Given this list of marker genes Spire1, Avp, Golph3, Bbc3, Ep300, Mgarp, Hdac6, Psmd10, Rala, Lmna, Hrk, Dcn, Gclc, Bax, Tmem102, Vat1, Dhodh, Moap1, Pde2a, Prelid1, Bok, Slc30a9, Huwe1, Tfrc, Cyrib, Bik, Bcl2l11, Bcl2l2, Carlr, Igtp, Aurka, Ghitm, Yme1l1, Ddhd1, Bnip3, Rhot1, Mtch2, Mtnap1, Mmp9, Stox1, Tnfsf10, Mapt, Hip1r (NCBI Gene Id 29816), Marchf5, Nol3, Bad, Stat2, Irgm1, Zdhhc6 (zinc finger, DHHC domain containing 6), Plscr3, Oma1, Pparg, Mpv17l, Dnm1l, Gsk3a, Micu1, Tmem135, Mief1, Fas, Fis1, Pld6, Siva1, Pla2g6, Pdcd5, Pycard, Arrb2, Trp53, Bmf, Fzd9, Akt1, Slc25a4, Vps35, Ssbp1, Bcl2l1, Chchd10, Ralbp1, Ppif, Inf2, Opa1, Ddhd2, Mief2, Prkn, Gsk3b, Acaa2, Atp5if1, 4930550C14Rik (NCBI Gene Id 75311), Pdcd5-ps, Ppargc1a, Mff, Tmem14a, Mcu, Gper1, 2610042L04Rik, Bid, Rap1gds1, Slc35f6, Fxn (NCBI Gene Id 14297), Pgam5, Pmaip1, Wdr35, Hgf, Pisd, Pink1, Mfn1, Mllt11, Parl, Higd1a, Endog, Mir539, Fam162a, Zfp13, Slc25a5, Gpx1, Sirt7, Triap1, Mfn2, Irgm2, Prmt6, Igf1, Slc25a31, Adck1, Bak1, Plaur, Mul1, Atp13a2, Kdr, Ier3, Myo19, here is a description of the gene set: studied in species Mus musculus Any process that modulates the frequency, rate or extent of a process involved in the formation, arrangement of constituent parts, or disassembly of a mitochondrion. Mouse Gene Set: GOBP_REGULATION_OF_MITOCHONDRION_ORGANIZATION